The following is a description of a gene set: Human Gene Set: MIKKELSEN_MEF_LCP_WITH_H3K4ME3 studied in species Mus musculus Genes with low-CpG-density promoters (LCP) bearing tri-methylation mark at H3K4 (H3K4me3) in MEF cells (embryonic fibroblasts). from publication Mikkelsen TS, Hanna J, Zhang X, Ku M, Wernig M, Schorderet P, Bernstein BE, Jaenisch R, Lander ES, Meissner A (PMID 18509334) Somatic cells can be reprogrammed to a pluripotent state through the ectopic expression of defined transcription factors. Understanding the mechanism and kinetics of this transformation may shed light on the nature of developmental potency and suggest strategies with improved efficiency or safety. Here we report an integrative genomic analysis of reprogramming of mouse fibroblasts and B lymphocytes. Lineage-committed cells show a complex response to the ectopic expression involving induction of genes downstream of individual reprogramming factors. Fully reprogrammed cells show gene expression and epigenetic states that are highly similar to embryonic stem cells. In contrast, stable partially reprogrammed cell lines show reactivation of a distinctive subset of stem-cell-related genes, incomplete repression of lineage-specifying transcription factors, and DNA hypermethylation at pluripotency-related loci. These observations suggest that some cells may become trapped in partially reprogrammed states owing to incomplete repression of transcription factors, and that DNA de-methylation is an inefficient step in the transition to pluripotency. We demonstrate that RNA inhibition of transcription factors can facilitate reprogramming, and that treatment with DNA methyltransferase inhibitors can improve the overall efficiency of the reprogramming process., and this is the list of marker genes: OLFML1, COL6A1, PLPPR2, ANGPTL2, IFIT1B, GAL3ST4 (galactose-3-O-sulfotransferase 4), PINLYP, XAF1, TNFRSF14, STYXL2, SOAT2, C1QTNF6, MRGPRF, GGNBP1, LDB3, TNKS1BP1, TMEM176A, TBXA2R, ARAP1, SERPINB8, CASP12, SNX10, SARDH, P2RX6, MR1, PHYHD1, CP, LSP1, C20orf96, SERPINB9, PDGFRB, ACTG2, OGN, HACD4, CAB39, ECSCR, VWA5A, ASPN, TLR4, ECM1, SPACA6, C1orf54, SCN2B (NCBI Gene Id 6327), TMEM176B, CYP2J2 (cytochrome P450 family 2 subfamily J member 2), ZFP57, TRIM21, POSTN, TNS2, MRPS21, BTC, GBP2, PSPN, PRICKLE3, ACOT11, PCOLCE, OSGIN1, GPR173, RAB7B, ANXA1, ARHGDIB, IL17RC, CAPG, COL3A1, XDH, ECM2, ELOVL1, HGF, EMP3, LGALS9, SH3KBP1, AKNA, RDH5, FHL1, IKBKE, SERPINF1, CYP4F8, SEC16B (SEC16 homolog B, endoplasmic reticulum export factor), WARS1, CCN5, RNF123 (ring finger protein 123), GPSM3, IQSEC2, GSTM1, DAPK3, GLMP, TREX1, CCN4, TAPBPL, PRRG2, MMP19, C6orf118, CASP4, IL1RN, PKIG, RAB43, SLFN12, LUM, CCL7, LPIN3, MYO7A, KIAA1671, GLRX, CCL2, TMEM248, ZSCAN2, DAB2IP, IFI35, EMILIN1, NNMT (nicotinamide N-methyltransferase), DDR1, ZMYM2, CCDC9 (NCBI Gene Id 26093), ZFAND6, MASP1, NYAP1 (neuronal tyrosine phosphorylated phosphoinositide-3-kinase adaptor 1), TEF, MAB21L3, FBXW10, LGALS3BP, RUFY4, ARHGEF11, ZNF583, DMPK, CPA6, IL18RAP, RNASE10, VEGFD, AMPD3 (NCBI Gene Id 272), INHBA